The following is a description of a gene set: Human Gene Set: HP_ABNORMAL_CIRCULATING_SULFUR_AMINO_ACID_CONCENTRATION Any deviation from the normal concentration of a sulfur amino acid in the blood circulation. studied in species Homo sapiens Abnormal circulating sulfur amino acid concentration, and this is the list of marker genes: MTR, MTHFD1, GNMT, MTHFR, SKIC3, SLC25A13, PRDX1, FAH, NFE2L2, ABCD4, MMACHC, TCN2, MCEE, GPHN, LMBRD1, MMADHC, SLC19A1, AHCY, MTRR, HCFC1, AASS, TFAM, MAT1A, CD320, ADK, CBS